Given this list of marker genes DNM1, USB1, FOXG1, SCNM1, HSPA9, GABRA5, WWOX, LAMB3, GABRB2, CDK19, ATP1A2, EVC2, PERP, GTF2IRD1, SCUBE3, CEP85L, NXN, MSX1, PARS2, TRIM37, SCLT1, CACNA1A, PACS2, SLC39A13, XYLT1, BBS4, CLDN1, CLTC, KDF1, EDA, PARN, PUS7, SLC38A3, RBM28, RTEL1, CPLX1, SLC1A2, PPP3CA, CEP290 (NCBI Gene Id 9707), AP3B2, TBX3, WDR35, GRHL2, SDCCAG8, METTL27, WDR19, TSPEAR, DKC1, LRP4, NKX2-1, SLC13A5, TTC8, BBS1, PORCN, POLR1C, KCNH1, ELN, CCDC28B, POLR3A, KCNC2, CLIP2, IFT52, SCN8A, SCAPER, DNAJC21, LIMK1, ARL6, FLNB, CTC1, NFKBIA, POLR1A, CEP152, FGD1, CTBP1, BBS5, MLXIPL, RNF13, UBE3C, IFT172, APC2, SMARCAL1, EP300, NTRK2, LMNA, GABRA2, RPS6KA3, DHDDS, IFT122, HECTD4, MID1, BCL11B, DVL3, GABRG2, GABBR2, MAPK8IP3, NPM1, WNT5A, NSD1, RMRP, BBS10, NELFA, ACTL6B, ZMPSTE24, CELF2, BBS12, ROR2, KCNA2, GTF2IRD2, MKKS, SYNGAP1, SCN1A, FGFR2, CDH1, FGF3, MKS1, CHSY1, NECTIN1, BAZ1B, NECAP1, IFT27 (intraflagellar transport 27), APC, DYNC2LI1, OTUD5, GRIN2D, IRF6, ADAMTS2, PIGL, EIF4H, BUD23, DALRD3, KDM6A, PIGG, OFD1, CNKSR2, BBS7 (Bardet-Biedl syndrome 7), NSD2, NHP2, TRAF6, CFAP418, FOXC1, GLI1, KMT2D, SCN3A, WDPCP, WNT10A, GRHL3, SZT2, TRAK1, POP1, PRKACA, KCNN3, DDX59, CEP19, IKBKG, RFC2, NOP10, CACNA2D1, PITX2, ATP1A3, GDF5, BBS2, EDAR, TINF2, CTSK, CKAP2L, TERC, KCNB1, NUS1, PRKAR1A, TBL2 (NCBI Gene Id 27203), IFT74, AARS1, DNAJC30, BBIP1, WRAP53, EVC, NPHP1, ATP6V1B2, LEMD3 (NCBI Gene Id 23592), PTH1R, FZR1, LETM1, ACOX1, ATP6V1A, LEMD2 (NCBI Gene Id 221496), CYFIP2, BBS9, TMEM270, SYNJ1, KIF1C, FZD2 (frizzled class receptor 2), KMT2A, CREBBP, POLR3K, GTF2I, PRKACB, MBTPS2 (NCBI Gene Id 51360), FGFRL1, FKBP6, LZTFL1, CACNA1B, NKX6-2, TP63, FGFR3, TYMS, STX1A, PPP2R3C, FBXO28, VPS37D, HCN1, SMG8, IRX5, EDARADD, TERT, MTX2, FGF10, UBA5, EEF1A2, DVL1, FOSL2, IFT43, YWHAG, NCF1, PIK3R1, TRIM32, TRPV3, POLR3B, TWIST2, HMGA2, FGF12, here is a description of the gene set: Hypodontia The absence of five or less teeth from the normal series by a failure to develop. Human Gene Set: HP_HYPODONTIA studied in species Homo sapiens